Given this list of marker genes KITLG, ZNHIT1, HMGB1, NUDT21, FOXC1, DHX36, ZBTB1, here is a description of the gene set: Human Gene Set: GOBP_POSITIVE_REGULATION_OF_HEMATOPOIETIC_PROGENITOR_CELL_DIFFERENTIATION species: Homo sapiens Any process that activates or increases the frequency, rate or extent of hematopoietic progenitor cell differentiation.